The following is a description of a gene set: Mouse Gene Set: PHESSE_TARGETS_OF_APC_AND_MBD2_UP from publication Phesse TJ, Parry L, Reed KR, Ewan KB, Dale TC, Sansom OJ, Clarke AR (PMID 18644872) We have previously shown that deficiency of the methyl binding domain protein Mbd2 dramatically reduces adenoma burden on an Apc(Min/+) background. To investigate the mechanism underlying this phenomenon, we have determined the effect of Mbd2 deficiency upon the phenotypes imposed by the conditional deletion of Apc in the small intestine. Microarray analysis demonstrated a partial suppression of the Wnt pathway in the absence of Mbd2. Mbd2 deficiency also influenced one immediate cellular consequence of Apc loss, with normalization of Paneth cell positioning. From a mechanistic perspective, we show that deficiency of Mbd2 elevates levels of the known Wnt target Lect2, and we confirm here that Mbd2 binds the Lect2 promoter in association with NuRD. Furthermore, we show that Lect2 is capable of functioning as a Wnt pathway repressor. These results therefore provide a mechanistic basis for the epigenetic control of adenoma formation mediated through Mbd2. Genes up-regulated in small intestine upon loss of both APC and MBD2. studied in species Mus musculus, and this is the list of marker genes: Ccl24, Gm45351, Mkrn2, 4930554H23Rik, Fndc9, Dapl1, Unc45b, Rsph4a, Cacna2d1, H2-M10.1, Trim12a, Rims4, Itpr2, Ttc36, Nkx2-1, H2-Ea, Spin1, Pycard, Chst9, Dynlt2a1, Tmem121b